Given this list of marker genes NKG7, KLRD1, TBX21, KLRB1, IL2RB, SLAMF7, here is a description of the gene set: Genes down-regulated in blood 3d and 7d vs 0hr in adults (18-45) (high IgM responders) after exposure to CN54gp140 adjuvanted with GLA-AF, time point 3D, 7D combined (identical signatures), administered i.m. species: Homo sapiens Systems biology approaches have recently provided new insights into the mechanisms of action of human vaccines and adjuvants. Here, we investigated early transcriptional signatures induced in whole blood of healthy subjects following vaccination with a recombinant HIV-1 envelope glycoprotein subunit CN54gp140 adjuvanted with the TLR4 agonist glucopyranosyl lipid adjuvant-aqueous formulation (GLA-AF) and correlated signatures to CN54gp140-specific serum antibody responses. Fourteen healthy volunteers aged 18-45 years were immunized intramuscularly three times at 1-month intervals and whole blood samples were collected at baseline, 6 h, and 1, 3, and 7 days post first immunization. Subtle changes in the transcriptomic profiles were observed following immunization, ranging from over 300 differentially expressed genes (DEGs) at day 1 to nearly 100 DEGs at day 7 following immunization. Functional pathway analysis revealed blood transcription modules (BTMs) related to general cell cycle activation, and innate immune cell activation at early time points, as well as BTMs related to T cells and B cell activation at the later time points post-immunization. Diverse CN54gp140-specific serum antibody responses of the subjects enabled their categorization into high or low responders, at early ( < 1 month) and late (up to 6 months) time points post vaccination. BTM analyses revealed repression of modules enriched in NK cells, and the mitochondrial electron chain, in individuals with high or sustained antigen-specific antibody responses. However, low responders showed an enhancement of BTMs associated with enrichment in myeloid cells and monocytes as well as integrin cell surface interactions. Flow cytometry analysis of peripheral blood mononuclear cells obtained from the subjects revealed an enhanced frequency of CD56<sup>dim</sup> NK cells in the majority of vaccines 14 days after vaccination as compared with the baseline. These results emphasize the utility of a systems biology approach to enhance our understanding on the mechanisms of action of TLR4 adjuvanted human vaccines. from publication Anderson J, Olafsdottir TA, Kratochvil S, McKay PF, Östensson M, Persson J, Shattock RJ, Harandi AM (PMID 29535712) Human Gene Set: ANDERSON_BLOOD_CN54GP140_ADJUVANTED_WITH_GLA_AF_AGE_18_45YO_HIGH_IGM_RESPONDERS_3DY_7D_DN